The following is a description of a gene set: Mouse Gene Set: GOBP_NEGATIVE_REGULATION_OF_CD4_POSITIVE_ALPHA_BETA_T_CELL_PROLIFERATION Any process that stops, prevents or reduces the frequency, rate or extent of CD4-positive, alpha-beta T cell proliferation. studied in species Mus musculus, and this is the list of marker genes: Cblb, Lgals9, Foxp3, Vsir, Tarm1, Ndfip1, Arg2, Cd274, Xcl1, Itch, Cd44, Tnfrsf14, Twsg1